The following is a description of a gene set: A protein complex composed of two identical immunoglobulin heavy chains of the IgE isotype and two identical immunoglobulin light chains, held together by disulfide bonds. An IgE immunoglobulin complex may be embedded in the plasma membrane or present in the extracellular space, in mucosal areas or other tissues, or circulating in the blood or lymph. Human Gene Set: GOCC_IGE_IMMUNOGLOBULIN_COMPLEX species: Homo sapiens, and this is the list of marker genes: IGLC1, IGLC6, IGKC, IGLC7, IGLC3, IGHE